The following is a description of a gene set: This event has been computationally inferred from an event that has been demonstrated in another species.<p>The inference is based on the homology mapping from PANTHER. Briefly, reactions for which all involved PhysicalEntities (in input, output and catalyst) have a mapped orthologue/paralogue (for complexes at least 75% of components must have a mapping) are inferred to the other species. part of: Signal Transduction Reactome Pathway: Signaling by Erythropoietin electronically inferred by orthology from the curated human pathway studied in species Mus musculus, and this is the list of marker genes: Epo, Shc1, Pik3r5, Gab1, Vav1, Pik3cb, Epor, Irs2, Grb2